The following is a description of a gene set: A sudden sensation of feeling cold. Human Gene Set: HP_CHILLS Chills studied in species Homo sapiens, and this is the list of marker genes: PKHD1 (NCBI Gene Id 5314), TBK1, HAVCR2, UNC93B1, GYPC, NLRP3, EPB42, CTLA4, HADHA, TICAM1, MVK, SPTB, EPB41, TNFRSF1B, TLR3, TRAF3, HADHB, CD28, SLC4A1, SPTA1, ANK1